The following is a description of a gene set: studied in species Homo sapiens Catalysis of the hydrolysis of a single C-terminal amino acid residue from a polypeptide chain by a mechanism in which water acts as a nucleophile, one or two metal ions hold the water molecule in place, and charged amino acid side chains are ligands for the metal ions. Human Gene Set: GOMF_METALLOCARBOXYPEPTIDASE_ACTIVITY, and this is the list of marker genes: CPE, CPN1, PEPD, AGBL1, CPXM2, FOLH1B, AGBL2, CPXM1, FOLH1, PRCP, CPZ, CPB2, MME, ACE, CPO, MATCAP1, VASH2, CPA5, ACE2, CPM, CPA2, CPB1, VASH1, CPA1, CPA3 (NCBI Gene Id 1359), CPD, AGBL3, CPA6, NAALAD2, AEBP1, AGTPBP1, AGBL4, AGBL5, PREP, CPA4